The following is a description of a gene set: Mouse Gene Set: ID2_TARGET_GENES species: Mus musculus from publication Yevshin I, Sharipov R, Kolmykov S, Kondrakhin Y, Kolpakov F (PMID 30445619) Genes containing one or more binding sites for (Id2) in their promoter regions (TSS -1000,+100 bp) as identified by GTRD version 20.06 ChIP-seq harmonization., and this is the list of marker genes: Mtrfr, Cks2, Pdcl3, Mtch2, Ulk2, Fbxl14, Mphosph9, Axin2, Vps36, Pabir1, Tnpo1, Psma2, Tjp2, Sap18, Tgif2, Pctp, Agfg1, Smarcd2, Zfp398, Lig4, Khdrbs1 (KH domain containing, RNA binding, signal transduction associated 1), Alyref2, Cep120, Gtf3a, Sae1, Pbk, Tmem104, Mtmr14, Afdn, Rock2, Dip2b, Pop7 (NCBI Gene Id 74097), Angel2, Fam219b, Tada2b, Mapkapk2, Gm12059, Heatr5a, Tmed4, Polr2j, Alg8, Phlda3, Zfp664, Emc3, Zcchc4, Hnrnph1, Fgf9 (fibroblast growth factor 9), Selenoi, Kifap3, Gm15420, Naa50, Ndrg3, Trmt1l, Katnip, Slc38a10, Fbxl8, Zmynd8, Zfas1, Usp3, Wdr70, Coq2 (NCBI Gene Id 71883), Birc5, Cfap43, Snord49b, Vps13c, Gm527, Snrnp27, Cc2d1a, Foxa3, Pnrc1, Mvd, Gpam, Gm9530, Yipf2, Taok2, Aacs, Gga1, Eef1d, Pigh, Tmem120b, Zbtb26, Vcf1 (VCP nuclear cofactor family member 1), Nudt13, Anxa5, Htra2, Sp3os, Smarca4, Wipi2, Tfeb, Klhdc4, Ppp1cb, Gm12743, Fhl4, Dok1, Sp3, Sirt7, Prpf3, Slx9, 2610005L07Rik, A330035P11Rik, Sec24c, Mmgt2, Retreg3, Lsm11, Snhg20, Tob1, Cep295, Snx18, Nup85, Kat2a, Camsap2, Zmym4, Ktn1, Rnf14, Vmp1, Cul7, Txnl4a, Dtnb, Nfat5, Mir203 (microRNA 203), Ahcyl1, Stau1, N6amt1, Chmp2b, Pola2, Tent4a, Akap8, Nrep, 2410002F23Rik, Wdr43, Ncoa3, Grcc10, Mir8109 (NCBI Gene Id 102465898), Cdt1, Tubg1, Rad54l2, Acaa1a, Palld, Slc44a1, Vapb, Hs6st1 (NCBI Gene Id 50785), Arhgef1, Carm1, Tent5c, Mm2pr, 2410021H03Rik, Odc1, Tsacc, Rad23b, Tsc22d1, Tmem177, Rint1, Ipo9, Hinfp, Pabpc4, Slk, Tti1, Stx12, Rap2a, Myd88, Cisd1, Klhl11, Srp9, Nipsnap2, Dag1, Dnajc3, Bcas2, Ube2d2a, Dcp1a, Sdhaf4, Patl1, Vgll4, Ap2a2, 1700041I07Rik, Morc3, Hilpda, Acap3, Erbb3, Icmt, Pgbd5, Gm15787, Kras, Hibadh, 4921531C22Rik, Pink1, Capns1, Tex2, Zfp568, Zbtb41, Man1b1, Hmox1, Anapc11, Vps37d, Zfp11, Akt1, Fra10ac1, Avpi1, Eapp, Snord49a, Nudt3, Kctd2, Mrps26 (NCBI Gene Id 99045), B3galnt2, Adprs, Ywhag, Arl8a, Pcyt2, Hps3, Gpc1, Eps15l1, Retreg2, Phf12, Srsf5, Hnrnpk, Pdik1l, Baz2b, Sppl2b, Gm11532, Amotl2, Gm10766, Hgs, Gm14963, Tcf19, Zfp148, Ptk2, Kmt5b, Rps6kb1, Ctbp1, Zfp882 (zinc finger protein 882), Ndufv1, Pmpca, Prmt3, Tmem259, Agap1, Sdf4, Plekha8, Mafg, Cep104, Cdc7, Ppfibp1, Jup, Pphln1-ps1, Rab35, C230096K16Rik, Enc1, Lrsam1, Acad8, A430005L14Rik, Cptp, Sec14l1, Xxylt1, Tpt1, Rnf19b, Eps15, Zscan29, Unc13a, Rpap1, Ankrd50, Ip6k2, Wif1, Aip, Ginm1, Cdiptos, P4ha1, Ppil4, Xpo5, Ralgapb, Ndufs6, Rtn3, Cox11, Stx1a, B230219D22Rik, Pard3, Nomo1, Fbf1, Sars1 (NCBI Gene Id 97063, seryl-tRNA synthetase 1), Gdpd1, Gm17484, Spen, Laptm5, Prcc, Tradd, Gm9929, Ccser2, Gm10785, Ddb1, Bfar, Myo5b, Mir3077, Cbl, Zbtb43, Spdye4b, Eif4a2, Npc1, Llgl2, Cops8 (COP9 signalosome subunit 8), Pccb, Cdipt, Donson, Polr1h, H6pd, Spg7, Rnf8, Ascc1, Tmem127, Lifr, Senp3, Sgta, Slc25a40, Airn, Gars1, Arhgap39 (NCBI Gene Id 28124), Actn4, Uspl1, Tex261, Gosr1, Spg11, 9130604C24Rik, Gm13610 (NCBI Gene Id 105244114), Naa12, Srrm3 (serine/arginine repetitive matrix 3), Tcf25, Zmynd19, Dph3, Gas2, Kif23, Lrrc59, Gm4890, Rnf157, Tsga10, Tbca, Uba52, Pgrmc2, Ccdc96, M6pr, Aldh7a1, Tex30, Dpy19l4, Safb2, Cdk10, Zmym6, Mtg1, Gga3, Atxn2l, Dolk, Arl16, Unc45a, Rps10, Fmn1, Ptpn14, Zfp652, Spag9, Ube2v1, Gm11613, Mrps24, Dffb, Zfp335os, Nat9, Brme1, Dnajc11, Hk2, Ro60, Srsf1, Rbbp8, Nr1h3, Nae1, Csnk1a1, Cux1, Cc2d1b, Flnb, Pa2g4, Mrps23, Pcbp2, H4c16, Pan3, Mdm2, Thyn1, Gna11, Yars2, Wnk1, Trir, Tmem201, Rbm47, Lamtor3, Mir130c, Pou2f1, Socs2, Map1lc3b, Zc3h11a, Ncaph, Actb, Zbed6, Kpna1, Smad4, Smg9, Cant1, Zbtb10 (zinc finger and BTB domain containing 10), Thap12, Rapgef2, Usp24, Fbxo46, C330018A13Rik, 9430015G10Rik, Zbtb6, Gpbp1l1, AA474408, Itpa, Pomk, Atp6v1h, Cuedc1, Suds3, Tkt, Fancd2 (Fanconi anemia, complementation group D2), Eif3k (NCBI Gene Id 73830), Park7, Coa5, Taok1, Rad23a, 4930473A02Rik, Rubcn (RUN domain and cysteine-rich domain containing, Beclin 1-interacting protein), Zfp768, Gm15559, Zfp976, Ilrun, Tdp1, Rmnd5a (required for meiotic nuclear division 5 homolog A), Gnb1l, Msantd5l, Herc4, Spop, Azin1, Notch2, Golga1, Nup50, Lrch3, Preb, Mrps7, 4930500F10Rik, Traf2, Tmem54, Rsbn1, Ccdc122, Rcc1, Golga4 (NCBI Gene Id 54214), Atf6, Ercc2, Gm15247, Tmco3, 1810019D21Rik, Rab37, Prmt6, Gm38293 (predicted gene, 38293), Vipr1, Adam19, Aebp2, Pts, 2010110E17Rik, Uchl5, Fam220a, Pou6f1, Ndufa8, Cdc42bpb, Gtf3c6, Fermt2, Mycbp, Cyrib, Tomm20 (NCBI Gene Id 67952), Ranbp1, Pagr1a, Trpm8, Zfp94, Cald1, Gm16876, Rad51ap1, Coro1c, Fastkd1 (NCBI Gene Id 320720), Rabif, Nup107, Mrpl12, Lnpep, Ndufb6, Pde8a, Usp47, N4bp2l2, Cmtr1, Kdm3b, Ezh1, Bbc3, Cisd2, Tardbp, Zbed4, Lyrm9, Rab5if, Fyttd1, Gm12474, Tcea1, Gm16083, Calm1, Socs4, Polr3e, Dnmt3bos, Vps51, Tubd1, Sfi1, Cnih1, Wwox, Sltm, Pfn1, Vps13a, Rnf139, Tssk6, Mthfd1, Zfp638, Hat1, Mesd, Ndufb10, Cirbp, Enpp4, 9330159M07Rik, Timm21, Ptch1, Cbx1, Trim25, Nfyb, Ncbp3 (NCBI Gene Id 97706), Mcrip1, Arl6ip4, Dnajc9, Tor1aip1, Mettl22, Alad, Tbpl1, Tnfsf13os, Ccdc127, Vps29, Gm26839 (predicted gene, 26839), 5830454E08Rik, Rnf115, Hipk3, Trim59, Spast, Dctn5, Junb, Eid2b, Mir6936, Atp5pd, Gm15627, Polh, Zbtb17, Atp5mc2, Slc27a4, Capg (capping actin protein, gelsolin like), Tspan5, Zbtb7b, Stard7, Ext2, Pgs1, H3f3b, Eftud2, Ptpa, Gm16759, Trappc9 (trafficking protein particle complex 9), Rb1cc1, Ipmk, Srcap, Stkld1, Prkag1, Gne (NCBI Gene Id 69688), 5430400D12Rik, Mtnap1, Ube2f, Gm15441, Sympk, Rprd1b, Septin9, Pcnx3, Snhg7os, Oxnad1, Memo1, Mrpl39, Gm17399, Dnase2a, Nudt1, Stk38 (serine/threonine kinase 38), Egln1, Cisd3, Uqcc2, Atp5f1d, Wdr45b, Mapk14, Abcf1, Tsen54, Ddx23, Rpl14, Gm13783, Kansl1, Gm12728, Sav1, Sergef, Orai1, Cop1, Slc25a36, Mis18a, Gm25541, Nup188, Cdc42ep3, Amfr, Mettl8, Gm25878, Commd5, Becn1, Gm13830, Eri1, Cdc42ep1, Cul4a, Tarbp1, Scamp3, Dtx2, 2310061I04Rik, Zfp36l2, Zscan25 (zinc finger and SCAN domain containing 25), Pik3c2b, Creld2, Trmt2a, Nt5m, Rhbdf1, Tm2d3, Rundc3a, Trappc13, Mrps16, Tent4b, Mgat2, Xrcc2, H1f2, Cd55, Zfp975, Atp6v1a, Asb8, Ints3, Pcbp1, Eef2k, Tmem39a, Acot13, Bop1, Arsk, Rras, Cnppd1, Mid1, Hdlbp, Thra, Ciao1, Tex14, Nme1, Rpl36, Pusl1, Large2, Stk24, Mettl21a, Ctnna3, Skic3, Pag1 (phosphoprotein associated with glycosphingolipid microdomains 1), Cct3, Dnajc14, Mettl18, Rapgef6 (NCBI Gene Id 77527), Crat, Usp12, B230322F03Rik, Gm24355, Ints10, Recql4, Otulin, Bag6, Eif3a, Cchcr1, Pds5b, Stxbp4 (NCBI Gene Id 320264), Ccdc92, Chmp6, Cdon, Tpst1, Pten, Gm10190, Znfx1, Map4k1, Ggct, 1810062G17Rik, Bambi, 1600020E01Rik, Stag1, Aup1, Mepce, Cog6, Coil, Top1, Tfb2m, Tcta, Usp43, Ube2n, Faf1, Rbpms2, Ubxn2a, Stat3, St3gal2 (NCBI Gene Id 20444), Hdgf, Ints11, Pex14, Thop1, Ctdspl2, Mageb3, Rpl27, Taf12, 6820431F20Rik, Kctd6, Safb, Pitpnb, Mrps18a, Arhgdia, Pgls, Runx1, Insig1, Mmaa, Wdhd1, Parp4, Ddr1, 1700088E04Rik, Ubr3, Letmd1, Lasp1, Raf1, Tjp1, Arid1a, D6Wsu163e, Zfta, Etnk1, Gm3807, Dusp7, Pgap1, Yes1, Fuca1, Bola3 (NCBI Gene Id 78653), Fbxo42, Ppp2r3d, Errfi1, Bpnt1, Tex19.1, Rpl36al, Uso1, Ptma, Tmem9b, B230206L02Rik, Ehmt1, Rnf149 (ring finger protein 149), Stx2 (NCBI Gene Id 269706), Rpl19, Arih2, Swt1, Adrm1, Mtmr7, Cyb5r4, Msl2, Wnt9a, Zfp800, Gmcl1, Phyhipl, Mtfr1l, Snora17, Atp7a, Git2, Rab15, Pdia5, Rnf114, Cacng2 (NCBI Gene Id 77978), Sec61a1, Aldh4a1, Nr1d1, Taf1a, Rbm39, Hexim1, Entr1, Usp21, Arpc3, Barhl1, Kif20b, Cldn4, Iba57, Rnf38, Cited2, Pgap3, Gpatch8, Firrm, Homer3, Gm7596, Mettl9, Golga3, Pafah1b1, Zc3h14, Plod2, Srsf2, Erbb2, Zfp213, Chmp2a, Zcwpw1, Mrpl20, Nkiras2, Mbd1, Mtmr2, Arf1, Ero1a, G2e3, Erlin1, Tesk2, Cln5, Rest (NCBI Gene Id 72127), Ndfip2, Cltc, Snap23, Vps18, Mlh3, Marchf7, Vars2, Rbm34, Sdc4, Cfap410, Ndufa6, Znrf1 (NCBI Gene Id 68110), Mir6236, Rasgef1b, Agtpbp1, Fgfr1op2, Atxn7l2, Mad1l1, Gca, Rab14, 5730471H19Rik, Lcorl, Ppp1r8, Gm27011, Psap, Cenpu, Slc16a1, Nadk, Kdm3a, AA914427, Txnip, Sbds, Fem1a, Ints2, H4c9, Lrrc8b, Hsf1, Fau, Pcid2, Lsg1, 6430573P05Rik (RIKEN cDNA 6430573P05 gene), Noc2l (NCBI Gene Id 99992), Tfap2c, Pafah2, Ralgapa2, Ctcf, H4c3, Trim41, 2310010J17Rik, Ube2z, S100a11, Polr2f, 1810037I17Rik, 5730420D15Rik, Gemin7, Rnf227, Upf1, Maml3, Castor2, Rpl12, Acadl, Wipf2, Casp2, Ccdc171, Akip1, Tdp2, Banp, Spo11, 3110040N11Rik, Gm5533, Tbc1d7, Suco (SUN domain containing ossification factor), Rbpj, Gm2479, H1f4, Gm29417, Emc10, Septin2, Naa35, Selenot, Fkbp1a, Alkbh5, Htra1, Gcfc2, Rhoa, Amt, Arpc2, Kdf1, Alyref, Slc2a1, Tbc1d24, Rplp1, Gata4, Alas1, Nprl3, Chd8, Klhl20, Elf2, Hmga1, Erp29, Ints5, Gorasp2, Rbbp8nl, Mbd3, Lamb2, Prkcz, Abca5, Nelfcd, Atp5f1c, Cblc, Fzd5, Tnks2, Clk4, N4bp1, Crtc1, Atl3, Arid3a, Tcn2, Clpx, Mgat5b, Srrm1, Adss2, Keap1, Gm10778, 9130017K11Rik, Acp2, Gm26608, Rpl7l1, Litaf, Mrpl58, Mastl, Fam118a (family with sequence similarity 118, member A), Gtf2h2, Usp42, Trpc4ap, Marchf8, Fignl1, Tgm1, Rab10 (RAB10, member RAS oncogene family), Ccdc43, Unc5b, Perp (PERP, TP53 apoptosis effector), Esrp2, Pigv, Loxl3, Gm14167, Srp68, Fam98a, Ranbp2, Pik3r2, Pcyt1a, Alg5, Gm15706, Wtap, Dhx8, Irf2bp2, Ep400, Fbxo5, Zfp280d, Plcb4, Nup54 (nucleoporin 54), Rnf187, Sil1, Rnf126, B3galt6, Nampt, Slc44a2, Cdc34, Zfp784, Fbxo31, Taf4, Endov, Zfp623, Get4, Armc6, Kin, D2hgdh, Dhx34, Tm9sf2, Rock1, Commd7, Picalm, Fbxo11, Pithd1, Tmx3, Scrt1, Xpo7, 2300009A05Rik, Wdsub1, Mrpl32, Tbrg4, Timm8b, Cep85, Ints14, Polr2c, Slc9a1, Ddhd2, Tlnrd1, Vac14, Pcmt1, Smarce1, Pomt1, Nras, Morn5, 1110006O24Rik, 4933405D12Rik, Slc35e3, Cox5b, Srp19, Bambi-ps1, Cnnm4 (NCBI Gene Id 94220), Cbarp, Acbd4, Ehd1, Pgam1, Tmem170b, Epb41l2, Mfap3l, Dusp22, Fitm2, Saysd1, Atg16l2, Sfpq, Tmem106c, Nsf, Eif2b4, Gm4285, Sdhd, Zbtb38, Brap, Slx4, Got2, Alg12, Rxra, Nfyc, Ppp1r3e, Gm15564, Rxrb, Pdrg1, Tmem101, Nsfl1c, Kctd13, Yme1l1, Exosc8, Tpk1, Fadd, Atl2, Lrrc14, Klf3, Ccdc103, Sys1, Hook2, Dbf4, Smap1, Copg1, Unc50, Polr2a, Mfsd11, Tmx1, Gm13421, Ei24, Epn3, Tigd5, Mga, Scaf8, Pdcd5, Ubr4, Dcaf17, Sde2, Ndel1, Nudt9, Brd2, Surf4, Dazap1, Upp1, Gm28043, Atn1, Ubxn7 (NCBI Gene Id 381042), Usp10, Rab3gap2, Parp6, Exosc4, Dedd2, Smarcc1, Ak1, Yif1b, Hes1, Hsp90aa1, Smurf2, Nlrx1, Gm28857, Arap2, Zfp652os, Ap3s2, Dpf2, Arrdc1, Ndufs7, Exoc8, Syde2 (NCBI Gene Id 214806), Tmem263, Aspscr1, Sprtn, Polr1has, Pcgf1, Mir7009, Bahcc1, Lrrc27, Pstk, Ssh1, Tex10, Abcd4, Tbkbp1, Rad21, 4732440D04Rik, Slc25a10, Bptf, Opa1, Pxk, Sdha (succinate dehydrogenase complex, subunit A, flavoprotein (Fp)), Vdac3, Ccna2, Gm13033, Txndc11, Gpr19, Rab18, Mif4gd, Gm11515, Cdkn2a, Man2b2, Arid3b, Ciao3, Sec24a, Urgcp, Lsm7, Dna2, Lrrc75a, Psmd5, Mob4, Rapgef1, Car7, Srr (NCBI Gene Id 27364), Hp1bp3, Arfgap1, Mapkbp1 (NCBI Gene Id 99332), Atp6v1b2, Golga7, Haus6, Chuk, Ptpre, G530011O06Rikx, Rabgap1, Rrp1b, 9130230L23Rik, Washc1, Fbxl3, Dll3, Abhd13, Wwp1, Phospho1, Snx17, Mrpl49, Lyzl4, Hjurp, Tecpr1, Fnbp4, Zfp609, 2410006H16Rik, Kansl3, Fpgs, Igf2bp1, Lats2, Iqgap1, Rrm2, Cdkn2aipnl, Cpsf1, Lacc1, Sugp2, Zmym1, Hdhd3, Gm43391, 1700007L15Rik, Dsn1, Gm26631, Ift46, Rmi1, Ing5, Atp5mj, 1700045H11Rik, Zdhhc12, Zfp143, Cog2, Dbp, Epha1, Pkmyt1, Tubgcp4, 5430405H02Rik, Map3k5, Tor1aip2, Snord118, Gtf2a1, Dync1li1, Acad10, Yeats4, Actg1, Zfp12, Gtf2f1, Cox7a2, Dynll1 (NCBI Gene Id 56455), Cep135, Ppp2cb, Rpl22, Wiz, Slc39a7, Dnmt1, Ube2s, Snap47, Eif1, Tmem116, Hmgxb3, Abhd5, Socs3, Polr3c, Set, Tyw1, Dhrs13, Rfc1, Anapc16, Cnst, Gale (galactose-4-epimerase, UDP), Mrs2, Sh3bp5, Mthfsd, Mir6516 (microRNA 6516), Rbak, Fam171a1, Trim23, Cmc1 (NCBI Gene Id 76537), 0610009L18Rik, Chd9, Laptm4b, Sh3gl1, Rab33b, 1700086P04Rik, Mgat4a, Prelid3b, Dvl1, Abca2 (NCBI Gene Id 98943), Eif2s2, Capn7, Gm26611, Rad9b, Snx7, Jmjd4, Odad4, Evl, Ark2n, Mir5122, Kdm1a, Gm57488, 5330439K02Rik, Cdx2, Pogk, H4c4, Uqcrc1, Psmd3, Gtf3c1, Garin5a, Snw1, Cenpj, Tmem134, Ppp1r9b, Nudt19, Gm26397, Igsf9, Cgn, Fbxl5, Polrmt, Zkscan8, Ccdc62 (NCBI Gene Id 639165), Grb2, Dcaf10, Gapvd1, Spock1, Gm4319, Lmnb1, 4930449I04Rik, Palb2 (partner and localizer of BRCA2), Haspin, Arl14ep, Ccar1, AI661453, Mknk1